The following is a description of a gene set: species: Homo sapiens Any process that modulates the frequency, rate or extent of extracellular matrix assembly. Human Gene Set: GOBP_REGULATION_OF_EXTRACELLULAR_MATRIX_ASSEMBLY, and this is the list of marker genes: MIR19A, PPARG, MIR483, HAS2, TGFBR3, MIR19B1, TIE1, SOX9, MIR9-1, MIR29B1, TGFB1, ANTXR1, MIR145, MIR98, NOTCH1, MIR18A, EMILIN1, TGFBR1, SMAD3, AGT, SMAD4, RGCC, MIR27B